The following is a description of a gene set: studied in species Homo sapiens from publication Chen Y, Wang X (PMID 31504780) Human Gene Set: MIR3200_5P Genes predicted to be targets of miRBase v22 microRNA hsa-miR-3200-5p in miRDB v6.0 with MirTarget v4 prediction scores > 80 (high confidence targets)., and this is the list of marker genes: STARD3NL, IARS1, KLRG1, ARFIP1, SFRP2, LIN28B (NCBI Gene Id 389421), EMP1, LRRC31, SCML2, SH3TC2, ARMH3, FNDC3B, DPY30, ANTXR1, DSG4, TOR1B, ARID3B, TENT4A, BEND6, ACTR1B, SLC6A2, SP8, MMP24, ZNF385B, ZZZ3, TRIM5, NT5DC1, MAML1, CHIC1, AAK1, RPS6KA6, CYTH3, CMAS, SENP1, LARP1B, ZSCAN12, SLITRK3, SENP7, ELP1, AMER2, YIPF6, CCN2 (cellular communication network factor 2), AMACR, GBP2 (guanylate binding protein 2), TPBGL, SCN11A, UNC80, ATOSB, GUCY1A1, ZC3H7A, DONSON, SEPSECS, DLC1 (DLC1 Rho GTPase activating protein), LCOR, TSPAN9, ACSL4, RBFOX1, ONECUT2, GIPC3, ATF3, CDK15, PRKAA1, UNC5C (NCBI Gene Id 8633), TAGAP, BOD1L1, ID1, OLA1, BCAT1, RGS18, LRATD1, SNX4, SGIP1